Given this list of marker genes Ercc4, Trp53bp1, Smarcd2, Pias4, Kmt5c (lysine methyltransferase 5C), Meiob, Trip12, Trpc2, Swi5, Tex12, Ube2v2, Eya4, Rfc4, Apbb1, Pot1b, Ercc2, Ube2v1, Taok3 (TAO kinase 3), Cdk7, H2ax, Poldip2, Trex2, Usp3, Cul4a (NCBI Gene Id 99375), Top3a, Recql, Actr5, Zcwpw1, Rnf111, Mrnip, Rhno1, Mcm7, Csnk2a2, Rnf126, Tfpt, Samhd1, Rnf138, Kat2b, Rad9a, Prmt6, Parp9, Fen1, C1qbp, Ercc6l, Mc1r, Asf1a, Ppp4r3c2, Cetn2, Uchl5, Ticrr, Emsy, Eny2, Trim28, Pot1a, Cbx8, Ino80d, Hrob, Xrcc3, Dpf3, Terb1, Tdg, Exosc10 (exosome component 10), Cebpg, Cdc5l, Rbbp4, Palb2, Smarca5, Pole2, Fancc, Kmt5b, Mcmdc2, Hmgb1 (NCBI Gene Id 15289), Uvrag, Msh5, Riox1, Setmar, Rfc1, Rpain, Nucks1, Paxx, Mcm4, Bcl7c, Rpa2, Mcm6, Sirt6, Taf2 (NCBI Gene Id 319944), Sfpq, Bcl7a, Ddx11, Rev3l, Huwe1, Ddb2, Khdc3, Shprh, Rad1, Xrcc6, Ube2d3, Dmap1, Phf10, Ercc6l2, Mta1, Taf6l, Rnf8, Polr2i, Polg, Smc6, Mre11a, Tdg-ps, Ino80, Fbxo6, Taf10, Uvssa, Smc2, Psmd14, Hmga1b, Ager, Ap5z1, Gtf2h2, Twist1 (twist basic helix-loop-helix transcription factor 1), Rad21l, Msh2, Chaf1b, Tmem161a (transmembrane protein 161A), Zfp668, Ttc5, Nscme3l, Msh3, Tonsl, Nhej1, Rad54l, Hltf, Rpa3, Cdc45, Smarcd1, Npm1 (nucleophosmin 1), Pagr1a, Rpa1, Skp2, Hinfp, Usp10, Tigar, Kdm2a, Actl6a, Tex15, Tex264, Sirt7, Exd2, Dmc1, Sf3b5, Sprtn, Hmga1, Rad51d, Taf12, Smarca4, Was, Fbxw7, Parpbp, Bcl7b, Pif1, Morc2b, Vcp, Pnp, Pole, Taf5l, Mcrs1, Cdc14b, Commd1, Eme1, Trex1, Rbbp8, Ppp4r3b, Usp7, Csnk2a1, Wdhd1, Npas2, Ggn, Mbd4, Ankle1, Peli1, Fto, Ogg1, Chek1, Msh6, Fgf10, Usp47, Xab2, Fignl1, Ufl1 (UFM1 specific ligase 1), Mms19, Xrn2, Pms2, Arid2, Meaf6, Brca1, Pola1, Smarcb1, Actr2, Babam2, Taok1, Slf2, Prpf19, Brcc3dc, Ints3, Tdp1, Prkdc, Zswim7, Rad21, Fancl, Axin2, Rnf138rt1, Etaa1, Helb, Eya1 (NCBI Gene Id 14048), Poli, Atrip, Suv39h1, Upf1, Ccdc117, Htatsf1, Hus1b, Rfwd3, Sycp3, Ube2w, Smc3, Eya2, Rtel1, Recql5, Mgme1, Ubr5, Spata22, Rbx1, Cdc7, Setd7, Pold3, Uimc1, Nipbl, Rmi2, Kat5, Ascc2, Polh, Pclaf, Fanci (Fanconi anemia, complementation group I), Ino80c, Ascc1, Ppp4r3a, Smarcad1, Zmynd8, Primpol, Gins4, Hpf1, Kdm4d, Rad17, Shld3, Shld1, Sem1, Brip1, Ppp4c, Brd7, Nbn, Ino80b, Faap24, Pnkp, Smug1, Shld2, Ssrp1, Fh1, Fam111a, Poln, Morf4l2, Rnf169, Ube2b, Meioc, Sycp1, Rrm1, Crebbp, Dot1l, Top3b, Mutyh, Spidr, Apex2, Sirt1, Rfc3, Supt7l, Trrap, Foxm1, Rnaseh2b, Mrgbp, Cdkn2d, Kif22, Mcm5, Mus81, Cgas, Dpf1, Terb2, Xrcc1, Atm, Apex1, Dhx9, Chek2, 4930447C04Rik, Radx, Arid1a, Swsap1, Dclre1c, Zmpste24, Ruvbl1, Smarce1, Atr, Taf7, Polg2, Eid3, Brme1, Setd2, Kat2a, Adprs, Dtl, Pcna, Polb, Mdc1, Gins2, Rmi1, Neil1, Polq, Rps3, Parp1, Ube2a, Ooep, Aunip, Smchd1, Cdk9, Dyrk1b, Prkcg, Dek, Inip, Fancf, Mlh1, Rif1, Tnks1bp1, Nabp2, Polk, Xrcc4, Alkbh1, Klhl15, Spire2, Pms1, Exo5, Smarcc2, Smarcc1, Babam1, Traip, Nudt16l1, Fbh1, Ing3, Kat7 (K(lysine) acetyltransferase 7), Wrap53, Brcc3, Nsmce1, Nfrkb, Paxip1, Mbtd1, Chd1l, Clspn, Ier3, Smarca2, Hsf1, Hmga2, Otud4, Chchd4, Nsmce3, Otub1, Smc5, Hsf2bp, Uhrf1, Recql4, Rad51, Gtf2h3, Iffo1 (intermediate filament family orphan 1), Pogz, Hmces (5-hydroxymethylcytosine (hmC) binding, ES cell specific), Kin, Nabp1, Majin, Taf6, Pttg1, Faap20, Aptx, Chrna4, Usp51, Trp53, Hmgn1, Usp28, Rad54b, Smg1, Neil2, Endov, Aktip, Rad23b, Zranb3, Plk1, Herc2, Mnat1, Fmn2, Eme2, Park7, Polm, Dclre1b, Rad51b, Firrm, Actb, Terf2ip, Mlh3, Sf3b3, Tdp2, Bod1l, Xrcc2, Actr8, Mms22l, Hus1, Rec8 (REC8 meiotic recombination protein), Rexo4, Usp9x, Kdm1a, Parp10 (NCBI Gene Id 671535), Xpc, Rnf168, Mpnd, Setx, Nme3, Alkbh3, Fzr1, Pds5b, Mpg, Dna2, Vcpip1, Rad18, Nthl1, Zfp365, Nsmce4a, Cdk2, Ppp4r2, Rev1, Ercc3, Egfr, Ube2n (ubiquitin-conjugating enzyme E2N), Atrx, Blm, Nsmce2, Hdgfl2, Jmy, Tada1, Hspa1a, Tada3, Fancd2 (NCBI Gene Id 78247), Pold4, Slx1b, Sfr1 (SWI5 dependent recombination repair 1), Ercc6, Pold1, Nsd2, Cenpx, Smarcal1 (NCBI Gene Id 98463), Brd8, Stub1, Cep164, Slx4, Wrnip1, Epc1, Ascc3, Chd4, Cenps, Prdm9, Aplf, Lig1, Rnaseh2c, Usp22, Neurl4, Actl6b, Smc1a (structural maintenance of chromosomes 1A), Bccip, Spo11 (NCBI Gene Id 98973), Stk19, Abl1, Macroh2a1, Pold2, Lig3, Ddx1, Marf1 (NCBI Gene Id 98041), Pml, Cdca5, Spire1, Phf13, Wrn, Zfyve26, Neil3, Ubqln4, Fancb, Mcm8, Gen1, Nop53, Ercc1, Parp3, Poll, Trip13, Bard1, Top2b, Topbp1, Dpf2, Epc2, Fus, Bend2, Fancg, Nono, Zbtb7a, Dclre1a, Ddb1, Fan1, Atxn7l3, Dtx3l, H2ac25, Xrcc5, Rad51ap1, Psme4, Ercc5, Mcm9, Gtf2h4, Atxn7, Cyren, Kmt5a, Helq, Rfc2, Rad9b, Mgmt, Ap5s1, Faap100, Hdac9, Exo1, Msh4, Rad51c, Timeless, Fmr1, Pwwp3a, Taf9, Eya3, Xpa, Parg, Esco2, Dntt, Ung, Yy1, Rrm2b, Abraxas1, Mcm2, Rad52, Ube2t, Eepd1, Wdr48, Fanca, Mad2l2, Tnp1, Ttf2, Ruvbl2, Rad23a, Ppp4r3c1, Sgf29, Hdac10, Usp45, Kash5, Smc4, Cul4b, Ercc8, Rnaseh2a, Usp1, Brca2, Chaf1a, Mcm3, Senp3, Zbtb1, Bach1, Prmt1, Slf1, Yeats4, Supt16, Lig4, Supt20, Alkbh2, Rfc5, Vps72, Parp2, Pds5a, Gtf2h5, Cinp, Ep400, Morf4l1, Zgrf1, Aste1, Fam168a, Smarcd3, Fancm, Pbrm1 (NCBI Gene Id 76748), Gtf2h1, Taf5 (TATA-box binding protein associated factor 5), Rad50, here is a description of the gene set: The process of restoring DNA after damage. Genomes are subject to damage by chemical and physical agents in the environment (e.g. UV and ionizing radiations, chemical mutagens, fungal and bacterial toxins, etc.) and by free radicals or alkylating agents endogenously generated in metabolism. DNA is also damaged because of errors during its replication. A variety of different DNA repair pathways have been reported that include direct reversal, base excision repair, nucleotide excision repair, photoreactivation, bypass, double-strand break repair pathway, and mismatch repair pathway. Mouse Gene Set: GOBP_DNA_REPAIR studied in species Mus musculus